Given this list of marker genes Gnpda2, Nagk, Extl2, Mdp1, Mgat1, Chi3l1, Uap1, Chit1, Gnpda1, St6gal2, Ogt, Pgm3, Chia1, Chst5, St3gal1, Chst2, Nanp, Slc35a1, Aldh1a1, Npl, Oga, B3galnt2, Uap1l1, Hexb, Renbp, B4galnt2, Cmah, Gfpt2, Gnpnat1, Aldh1a7, Chst4, Gfpt1, Chil4, Gne, Ctbs, Chst7, Chst3, St6gal1, Ovgp1, Amdhd2, Dpagt1, Nans, Chil3, Mgat3, Fn3k, Csgalnact1, Chil6, Chst1, Chil5, Cmas, here is a description of the gene set: studied in species Mus musculus Mouse Gene Set: GOBP_AMINO_SUGAR_METABOLIC_PROCESS The chemical reactions and pathways involving any amino sugar, sugars containing an amino group in place of a hydroxyl group.